The following is a description of a gene set: Any process that modulates the establishment or extent of a membrane potential in the polarizing direction towards the resting potential, usually from positive to negative. Mouse Gene Set: GOBP_REGULATION_OF_MEMBRANE_REPOLARIZATION species: Mus musculus, and this is the list of marker genes: Scn1b, Cacnb3, Cav3, Scn5a, Kcne2, Kcne5, Nos1ap, Gja5, Wdr1, Adcy10, Nedd4l, Akap7, Ank2, Akap9, Nppa, Kcnj2, Kcna5, Cacna1d, Kcne1, Casq2, Flna, Kcnq1, Scn4b, Cav1, Kcnh2, Rnf207, Kcnh6, Zmpste24, Ywhae, Akap6, Kcne4, Snta1, Gja1, Kcne3, Cacna2d1